Given this list of marker genes Gm26390, Gabrg3, Gm24952, Nipa2, Gm26097, Gm24219, Gm24872, Gm23944, Gm24862, Mir6389, Gm24654, Gm18127, Gm26366, Gm26482, Snhg14, Gm22252, Gm17838, Gm34121, Snurf, Gm24116, Gm23560, Gabrb3, Snord116l17, Gm22912, Gm23687, Gm22996, Gm17907, Gm24585, Atp10a, Ube3a, Gm22630, Gm18453, Gm9377, Gm25741, Gm22524, Gm22941, Gm25742, Gm26230, Gm18129, Gm26499, Gm22812, Snord116l9, Snord107 (small nucleolar RNA, C/D box 107), Gm22851, Gm25121, Gm22417, Gm25463, Gabra5, Gm18642, Gm22496, Gm24657, Gm25988, Gm22285, Gm25585, Gm24027, Gm7367, Herc2, Gm22393, Gm22047, Gm24021, Gm25462 (predicted gene, 25462), Gm26334, Gm24702, Gm17984, Gm23265, Gm22627, Gm24566, Gm24759, Gm9373, Snord64 (NCBI Gene Id 100217429), Gm24866, Gm22449, Cyfip1, Gm9375, Rps12l1, Gm23619, Gm23254, Gm25499, Gm22050, Gm25350, Gm25523, Gm26201, Gm34272, Gm26096, Snord116l15, Gm25984, Tubgcp5, Gm7394, Gm24528, Gm25210, Gm24711, Gm6290, Gm18908, 4833421K07Rik, Gm24153, Gm5596, Gm9962, Gm26498 (NCBI Gene Id 115486642), Gm22373, Snrpn, Gm30196, Gm22511, Gm25089, Gm24206, Snord116l7, Nipa1, A230056P14Rik, Snord116l1 (NCBI Gene Id 64244), Snord116l3, Gm22863, Gm22909, Gm22584, Gm26392, Gm5776, Gm23911, Gm6226, Snord116l12, Gm23922, Gm22640, Gm25157, Gm22629, Gm23688, Gm26434, Gm9367, Gm23575, Gm26059, Oca2, Gm3198, Gm10297, Gm26433, Gm26504, Snord116l2, Gm17987, Gm26200, Gm19187, Gm23356, Luzp2, Siglech, Snord116l8, here is a description of the gene set: studied in species Mus musculus Mouse Gene Set: chr7B5